Given this list of marker genes Necab1, Foxj3, Flnb, Ube2n, Rpl37a (ribosomal protein L37a), Rasl11a, Jmjd1c, Onecut2, Bicral, Ntng1, Hrh3, Mamld1, Arhgef3, Map10, Mfsd14a, Mapk8, Klkb1, Mab21l1, Cxcl5, Mfap3, Ube2b, Ociad2, Cndp1 (carnosine dipeptidase 1), Kansl2, Rela, Rnpc3, Prdm8, Zfp808, Tsg101, Peli1, Ptprk, Tceal1 (transcription elongation factor A (SII)-like 1), Snap29, Cdk6 (NCBI Gene Id 330039), Tmem108, Tex9, Slc38a2, Plekha3, Trim33, H1f0, Grpr, Msl2, Hmgn1, Galc, Tiparp, Pde7b, Rab9b, Ap3m1, Pgr15l, Map1b, Commd4, Atp1b1, Zfp935 (NCBI Gene Id 71508), Scai, Olfml2b, Hhip, Nckap1, Gm5141 (NCBI Gene Id 380850), Cd5, Ttl, Plekhh2, Mapk1ip1l, Zfp738, Fnip1, Tmem60, Thsd7a, Afdn, Fbxo30, Tsc22d2, Pnn, Araf, Tnfsf13b, Zfp281, Gfi1 (NCBI Gene Id 14581), Thrb, Ralgps1, Pcsk6, Unc5c, Ddx3y, Zfp974, Vps39, Zfp386, Shcbp1, Hmcn1, Zfp760, Ddx3x, Rtf1, Eda2r, Rtl3, Nt5c2, Megf11, Atp2c1, Nktr, Igdcc4 (immunoglobulin superfamily, DCC subclass, member 4), Hycc1, Lhx2, Ttc14, Clasp1, Yeats2, Sgms2, Rnf24, Csnk1g1, Zc2hc1b, Ccr5, Fmn1, Ltbr, here is a description of the gene set: from publication Chen Y, Wang X (PMID 31504780) species: Mus musculus Genes predicted to be targets of miRBase v22 microRNA mmu_miR_3572_3p in miRDB v6.0 with MirTarget v4 prediction scores > 80 (high confidence targets). Mouse Gene Set: MIR_3572_3P